The following is a description of a gene set: Binding to a cluster of atoms including both metal ions and nonmetal atoms, usually sulfur and oxygen. Examples include iron-sulfur clusters and nickel-iron-sulfur clusters. Mouse Gene Set: GOMF_METAL_CLUSTER_BINDING studied in species Mus musculus, and this is the list of marker genes: Rsad2, Isca1 (iron-sulfur cluster assembly 1), Mocs1, Prim2, Aox4, Gsta1, Fxn, Nfu1, Glrx3, Nubp2, Sdhb, Rtel1, Ciao3 (NCBI Gene Id 67563), Ndufv2, Ireb2, Aifm3, Nubp1, Etfdh, Ndufs2, Gsta13, Pold1, Isca2, Glrx2, Dph1 (diphthamide biosynthesis 1), Aox3, Nthl1, Aco1, Slc25a39, Gsta2, Rev3l, Gsta5, Cisd1, Rsad1, Gstp1, Uqcrfs1, AK157302, Ndufv1, Ndufs1, Fdx1, Gstp-ps, Dpyd, Cisd2, Cdkal1, Ciapin1, Xdh, Aox1, Ndufs7, Iscu, Polr3f, Ddx11, ENSMUSG00000125816, Ppat, Fech, Cmah, Fbxl5, Tyw1, Kif4, Mutyh (NCBI Gene Id 70603), Exo5, Abce1, Rfesd, Glrx5, Dph2, Aco2, Abat, Gstp3, Elp3, Aox2, Pole, Nubpl, Ndufs8, Lias, Dna2, Nfs1, Brip1, Mettl17, Ercc2, Bola2, Gstp2, Cisd3, Cdk5rap1, Fdx2